Given this list of marker genes PLA2G2E (phospholipase A2 group IIE), PLA2G4F, PLA2G2F, PLA2G3, PLA2G4B, PLA2R1, LPCAT2, PLA2G10, LPCAT4 (NCBI Gene Id 91188), PLA2G4D, PLA2G2A, PLA2G5, PLA2G6, TMEM86B, PLA2G12A, PLA2G4E, PLA2G4A, PLAAT3, MBOAT2, PLA2G1B, LPCAT1, PNPLA8, PLB1, PLA2G4C, PLBD1, PLA2G2D, LPCAT3 (NCBI Gene Id 10162), here is a description of the gene set: Reactome Pathway: Acyl chain remodelling of PC part of: Glycerophospholipid biosynthesis species: Homo sapiens In the acyl chain remodelling pathway (Lands cycle), phosphatidylcholine (PC) is hydrolysed by phopholipases and subsequently reacylated by acyltransferases. These cycles modify the fatty acid composition of glycerophospholipids to generate diverse molecules asymmetrically distributed in the cell membrane.